The following is a description of a gene set: studied in species Homo sapiens FRS-mediated FGFR4 signaling Human Gene Set: REACTOME_FRS_MEDIATED_FGFR4_SIGNALING, and this is the list of marker genes: FGF17, NRAS, FGFR4, KLB, FGF9, GRB2, FRS2, FGF4, FGF1, FRS3, KRAS, FGF6, SOS1, FGF2, PTPN11, FGF23, FGF19, FGF8, FGF18, FGF20, FGF16, HRAS